Given this list of marker genes KIF2A, KIF1A, KIF15, DYNLT5, DYNC1I1, DYNLL2, DNAH17, ACTR1B, BIRC5, HAUS7, HAUS2, APPBP2 (NCBI Gene Id 10513), DYNC1LI1, FBXW11, KIF4A, KIF25 (NCBI Gene Id 3834), MAP1A, EML1, RP1, DNAI7, DNAH9, DNAL4 (dynein axonemal light chain 4), DYNC1H1, KIF20B, INCENP, DNAH6, HAUS6, KATNBL1, DNAH5, AURKA, TRIM54, HAUS8, KIF6, KIF22, DNAH11, DNHD1, KIF3C, DRC1, DISC1, DYNLRB1, KLC1, KIF27, KIF14, DCTN4 (NCBI Gene Id 51164), KLC3, KIFC2, DNAL1, SHTN1, MAP7, KIF20A, KIF21B, KIF23, DNAH12, KIF21A, KIF17, ACTR1A, MAP1S, DNAH2, KIF5C, MID1, KIF1C, KIF19, KIF3A, FNTB, DNAI1, KIF28P, HAUS1, DYNC2H1, NME8, DNAH3, DYNLT2B, KLC4, STAU1, LRP8, TTBK1, DYNLL1, KIF11, AURKB, EML2, KIF18A, DYNLT2, PEA15, KATNAL2, DYNLRB2, DYNC1LI2, DCX, DCTN1, DNAI3, KIF3B, PXN, TPR, DYNLT4, ODAD1, DNAH10, KIF13A, GABARAP, DNAI2, NDEL1, HDAC6, KLC2, MAP2, RANBP9, KIF18B, KIF5B, KIF7, KIF4B, CCDC65, DYNC2LI1, DNAH1, CFAP70, KIF2C, NUDCD3, AURKC (aurora kinase C), SNX4, CLIP2, DYNC2I2, KIF1B, HAUS5, FNTA, HAUS4, DYNC2I1, RABGAP1, BORCS5, KIF9, KIFC3, KIF2B, DCTN6, NDE1, PAFAH1B1, DCTN2, KIF5A, DYNLT1, KATNB1, HAUS3, DNAH7, CCDC103, DNALI1, CDCA8, DCTN3, KIF16B, DYNC1I2, KIFAP3, MAP1B, DNAH8, MEFV, DCTN5, DYNLT3, KIF13B, KIF12, SPTBN5, KATNA1, KATNAL1, KIFC1, ACTR10, MAP4, DNAI4, DNAH14, here is a description of the gene set: studied in species Homo sapiens Any multimeric complex connected to a microtubule. Human Gene Set: GOCC_MICROTUBULE_ASSOCIATED_COMPLEX